The following is a description of a gene set: Genes down-regulated in HMC-1 (mast leukemia) cells: untreated versus stimulated with T cell membranes. Human Gene Set: GSE19888_CTRL_VS_T_CELL_MEMBRANES_ACT_MAST_CELL_DN studied in species Homo sapiens We demonstrate that the G protein Gi3 is the cellular target of the adenosine A3 receptor (A3R). By using a cell permeable peptide comprising the C-terminal end of Gαi3 fused to an importation sequence (ALL1) as a selective inhibitor of Gi3 signaling, we show that by coupling to Gi3, the A3R stimulates multiple signaling pathways in human mast cells, leading to upregulation of cytokines, chemokines and growth factors.Following contact with activated T cell membranes, endogenous adenosine binds to and activates the A3R, resulting in Gi3-mediated signaling. Specifically, the majority of ERK1/2 signaling initiated by contact with activated T cell membranes, is mediated by Gi3, giving rise to ALL1-inhibitable cellular responses. These results unveil the physiological GPCR that couples to Gi3 and establish the important role played by this G-protein in inflammatory conditions that involve adenosine-activated mast cells. We used microarrays to detail the effect of ALL1 on gene expression of HMC-1 cells activated directly by the A3 receptor, or by contact with activated T cell membranes. from publication Baram D, Dekel O, Mekori YA, Sagi-Eisenberg R (PMID 20190146), and this is the list of marker genes: TTPAL, NDUFS1, CBLC, NLRX1, ZBTB22, TCF20, KDM5B, SORCS2, INTS15, DSG1 (desmoglein 1), ESRP2, NRDC, MAP2, PRKCH, WIPI2, PAIP2, ITGA6, NAA35, LAPTM4B, PLEK2, DLX3, MBOAT1, KLF5, ZMAT3 (zinc finger matrin-type 3), SPINT1, CD109 (CD109 molecule), USP34, NRIP3, PSTK, PLXNA2, DSC3, MYH2, SEC14L2, MAB21L4, SQLE, WFDC5, RALGAPA1, ABTB3, PROM2, CHMP2A, EDRF1, CLIC3, GPSM2, DAPL1, STRIP1, PPM1D (protein phosphatase, Mg2+/Mn2+ dependent 1D), MINDY2, RAB38, RPL18A, KLK5, MFHAS1, PKP1, RALBP1, PLCXD2, TMEM79, SAR1B, LTA4H, CBR3 (carbonyl reductase 3), ZC3H6, HELLS, HEBP2, PPP1R17, NIPAL2, FBXO38, IL1A, PLA2G4F, FBXO32, AQP9, COQ8A, KLK11, TOPBP1, RAI14, PPP3CB, ALOX12B, BTBD3, MICALL1, LRCH1, MYH14, USP54, PRRG2, NOTCH1, GPRIN2, ATP10B, GPR87, MUS81, NEMF, SKIL, SKIC8, SFN, FNDC5, MFSD4A, PTK6, SPRY1, MCTP1, AMZ2, SERPINB11, MAGIX, IP6K2, CYB561, ARHGEF37, SDC1, TRNT1, ZCCHC3, ZSWIM1, GRB7, ERBB3, IL18, MALL, MPZL2, ADRA1A, ANKRD13C, PIGG, EDC3, TRIB1, SLC6A4, MARVELD2, LORICRIN, SH3RF2, SERPINB5, HOXA5, ASB14, CERK, GRHL3, MYLK2, CSRNP2, EIF2AK4, AMPH, NDFIP2, FAM83G, SMPD3, DSTN, BTBD7, PDLIM2, RHBG, ARHGEF26 (Rho guanine nucleotide exchange factor 26), GJB4, ID4, LDHB, ZFYVE9, PES1, C15orf62, P2RY1, DMKN, LRP2BP, ZNF18, FAM83H, AREG, IGSF9, PEBP1, DCAF1, ABCD3, GRHL2, FAM25C (family with sequence similarity 25 member C), CDSN, ELOVL6, SH3YL1, GPBP1, CCDC24 (NCBI Gene Id 149473), THEM5, SERTAD1, CTDP1, ZSCAN10, PTPN3, TMPRSS11F, MBNL3 (muscleblind like splicing regulator 3), CLPX, FGFR2, MTMR11, CKMT1B, NDRG2, MINK1, MPZL3, GCNT2, GJB5, PNMA1, UCHL3, OR8A1, ACTN1, LIPK, RAB3D, NPAT, KRT10, PURB, MAP2K4, PSRC1, SMARCA4, S100A14, STARD7, C1orf210, SLC35A3 (NCBI Gene Id 23443), NFKBIA, NCK2, AJUBA, STYX, HOMER2, CYB5R4, PPL, SCEL, NRTN, RABGGTA